The following is a description of a gene set: An abnormal resistance to glucose, i.e., a reduction in the ability to maintain glucose levels in the blood stream within normal limits following oral or intravenous administration of glucose. species: Homo sapiens Human Gene Set: HP_IMPAIRED_GLUCOSE_TOLERANCE Impaired glucose tolerance, and this is the list of marker genes: NR3C1, SLC5A1, SLC40A1, AIP, KLF11, NEUROD1, ESR1, MAFA, TP53, NSMCE2, BLK, LMNA, ATRX, INS, BRAF, INSR, HNF1A, GCK, HNF1B, PAX4, IFT172, SLC5A2, SLC2A2, KCNJ11, CDH23, USP48, PDX1, HNF4A, USP8, WFS1, ABCC8, PSMB8, POLG2, CEL, CAV1 (NCBI Gene Id 857), LRP6, APPL1